Given this list of marker genes LRP6, WNT3, RECK, GSK3B, LRRK2, AXIN1, LRP5, WNT2, APC, DVL1, FZD1, ADGRA2, CTNNB1, here is a description of the gene set: Human Gene Set: GOCC_WNT_SIGNALOSOME A multiprotein protein complex containing membrane-localized Wnt receptors and cytosolic protein complexes, which is capable of transmitting the Wnt signal. Contains at least a Wnt protein, LRP5 or LRP6, a member of the Frizzled (Fz) family, Axin and and a Dishevelled (DVL) protein. studied in species Homo sapiens